The following is a description of a gene set: A structural anomaly of the olfactory lobe, the structure within the brain that receives neural input from the nasal cavity and thereby processes the sense of smell. Human Gene Set: HP_ABNORMAL_OLFACTORY_LOBE_MORPHOLOGY Abnormal olfactory lobe morphology studied in species Homo sapiens, and this is the list of marker genes: EDNRB, PEX1, MKS1, EDN3, ANOS1 (anosmin 1), SOX10, PIGA, MITF